The following is a description of a gene set: species: Mus musculus from publication Cui A, Huang T, Li S, Ma A, Pérez JL, Sander C, Keskin DB, Wu CJ, Fraenkel E, Hacohen N (PMID 38057668) Genes negatively differentially expressed in cell type: Monocyte upon treatment with cytokine: IL-2 in mouse lymph nodes in vivo. Mouse Gene Set: CUI_MONOCYTE_IL2_RESPONSE_DN Cytokines mediate cell-cell communication in the immune system and represent important therapeutic targets. A myriad of studies have highlighted their central role in immune function, yet we lack a global view of the cellular responses of each immune cell type to each cytokine. To address this gap, the authors created the Immune Dictionary, a compendium of single-cell transcriptomic profiles of more than 17 immune cell types in response to each of 86 cytokines (>1,400 cytokine-cell type combinations) in mouse lymph nodes in vivo. A cytokine-centric view of the dictionary revealed that most cytokines induce highly cell-type-specific responses. For example, the inflammatory cytokine interleukin-1β induces distinct gene programmes in almost every cell type. A cell-type-centric view of the dictionary identified more than 66 cytokine-driven cellular polarization states across immune cell types, including previously uncharacterized states such as an interleukin-18-induced polyfunctional natural killer cell state., and this is the list of marker genes: Klf2, Foxred2, Fos, Sat1, Slc38a2, H2ac24, Klf4, Fosb, Rgs2, Slirp, Ggt5, Cep57l1, Gimap6, Actr5, Meaf6